Given this list of marker genes DDIT3, HBEGF, EMC10, GRTP1, PPP1R10, HROB, MAFA, DPPA5, FGF1, HSPB8, HADH, UCK1, FBXO15, ACTN4, PAK5, AANAT, VARS1, NHLH2 (nescient helix-loop-helix 2), RARB, ADGRG5, CAPNS1, JUNB, OXNAD1, ZSWIM1, CSF2RA, BHLHE40, CYSTM1, ACP6, FGF4, CFL2, DUSP9, FOXA1, ITPK1, ZEB2, LACTB2, NEK2, MBD3, PDK1, SRC, LSR, RPS8, KCNC1, C22orf15, CIDEA, EVA1B, MSH6, MREG, RIN2, ZIC5 (Zic family member 5), GPC4, EBF4, BARHL1, MYCN, BABAM2, FN1, ADGRE5, FAM120C, TLX2, SET, CCP110, TOP2B, SNTB2, INSYN1, MDK, AMT, SKIL, PIDD1, MEGF11, FXN, REEP3, ECT2, RASAL3, PTCH1, SALL2, MRPL37, ARG1, CFAP20DC, KAT7 (NCBI Gene Id 63437), ERAS, GLRA2, ZRSR2, LIM2, AEBP2 (NCBI Gene Id 121536), WIZ, FARSA, RIF1, PEF1, CST3, RHOF, CRELD1, CRIPTO, PLEKHB1, LRRC61, TSPAN9, GSPT2, GPRC5A, PRMT8, HS3ST3B1, AGTPBP1, RBKS, KRCC1, UBAP1 (NCBI Gene Id 51271), RESF1, G6PC2, KLF2, PYROXD1, ABCB8, AIPL1, SLC28A1, CEBPA, CELSR3, RB1CC1, ZFYVE28, PDGFRB, DYRK3, MYBL2, PPP5C, PRAG1, CPSF4L, FOLR1, OTUD7B, RREB1, RBM41, CFAP161, GSR, SH3BP1, PURB, FRAT1, TMEFF1, SIGIRR, MOK, UTF1, MEIS2, MED21, EVA1A, TCL1A (TCL1 family AKT coactivator A), NACC2, ALKBH7, SRP14, TMEM127, TMEM60, NODAL, RASL10B, ARF4, SPP1, POLR1A, TRH, NUDT4, TMPRSS6, PIMREG, MOBP, ATXN2, ZNF219, BMP4, SPIRE2, CCDC102A, THNSL2, ZC3H3, SPRED1, SLC9A8, ATP11B, ATG14, EIF3L, LGI2, IFITM1, WRAP53, PDLIM1, GRHL3, DCAF4, SDHA, DISC1, LEFTY1, GNL3L, COPS6, ITGA5, TCTN1, DAG1, CSN3, ZNF710, BCKDHA (NCBI Gene Id 593), POU2F3, S1PR2, LIPE, RNF5, ST3GAL3, HNRNPAB, NDUFA4L2, ADGRA2, MDM2, TCF7L2, MYL11, GDE1, CD37, HOXA4, FIGNL1, AMACR, SPRY2, AKAP1, PCGF2 (polycomb group ring finger 2), UBXN2A, COBL, SLAMF8, ZNF76, C9orf152, GLI1 (GLI family zinc finger 1), PLCB3, DLEU7 (NCBI Gene Id 220107), GCA, GPATCH3, ZNF438, CAMK1D, SRSF6, DENND2D, MGAT3, RBP1, DUSP1, PIGL, HOXB4, BRWD1, CFAP91 (cilia and flagella associated protein 91), YWHAG, PTPN6, CNOT9, ANP32A, KIAA1755, UPP1, FAM32A, MUC1 (NCBI Gene Id 4582), INHA, RAB8A, BRSK1, TRIM16, PLA2G10, DUSP4, SPRED2, HSD17B14, CDH1, SLC15A1, GTF2H1, TRIM7, RTBDN, RMND5B, RHBDD2, AS3MT, TM7SF3, SERPINF2 (NCBI Gene Id 5345), DHRS3, SLC25A51, PBX2, INTS3, WNT1, GSE1, RBM14, HMBS (hydroxymethylbilane synthase), TAFA4, HLF, MSLN, ST6GALNAC6, PLXDC1, TYROBP, CRYZL2P, SPATA33, MTSS1, STEAP3, GPA33, FAM91A1, AGPAT3, HOXB13, SBNO2, SPINT4, FEM1B, SULF2, PLK3 (NCBI Gene Id 1263), MME, SMARCD1, ZIC2, MRPL51, ZMIZ1, IER2, UQCRC1, IL3RA, LRRC2, KSR1, SDHD, SLC35D1, B3GNT7, TRIM28, KLHDC7A, ATF3, CYB5RL, GCH1, MBP, RAB10, HOXB1, CIMIP2C, CA4, COG6, DENND10, UBXN8, PPDPF, HOXA5, ENPP4, PPP1R14B, EFNA1, PDCL3, NR6A1, RAI1, HYAL1, MIEF1, KIT, CXCR3, TCP11, MBD6, METTL27, RHOXF2B, TMEM63C, STAT4, FHIP2A, GADD45G, CCN2 (NCBI Gene Id 1490), KDM6B, SMYD1, RNF125, RBPMS, TXLNG, PICK1, WEE1, TEX21P, GDF3, PIK3IP1, H1-2, SLC39A14, STK35, IQGAP3, IFITM2, RHOQ, COL4A1, ENAH, AGPAT1, FAM25A, C1QA, WDR91, ATP5F1E, WFDC2, RITA1, TMEM253 (transmembrane protein 253), AP5S1, G0S2, OTUD5, SPC25 (NCBI Gene Id 57405), NOTCH4, GFOD1, NANOS3, TCF19, VAT1, TRIM17, TLE5, CLN8, ANKRD28, TP53, GTPBP4, PIM3, WSB2 (NCBI Gene Id 55884), PDPN, POU5F1, STK11, PTPRF (NCBI Gene Id 5792), RXRB, PCGF1, PPP1R15B, CALR, FAM171B (NCBI Gene Id 165215), KANK3, SDK1, CLPB, MIS18BP1, SLC12A7 (solute carrier family 12 member 7), ALPL, MCL1, SLC35F2, DEDD, MASP2, PHC1, ZNF770, APOBEC2, GHDC, LEFTY2, SLX1A, TMEM135, UBE2O, GBX2, DACT2, DENND2C, COX17, PORCN, BCAT2, C9orf153, CTSD, SLC7A15P (NCBI Gene Id 100301573), CENPM, RAB20, NR0B1 (nuclear receptor subfamily 0 group B member 1), ING1, GJA1, LRRC75A, SHISA5, DPH3, OAS2, MTHFD1, PTH1R, SMAP2 (small ArfGAP2), GIPC2, ATP2A2, NCOR1, MACO1, MAPK1IP1L, IGFBP2, NFIB, LIN28A, C1orf210, FGF8, NBL1, SOCS3 (suppressor of cytokine signaling 3), AGTRAP, DNAJB6, STRA8, SAMTOR (NCBI Gene Id 154743), IDH3B, ACKR3, ZNF280B, RHD, RPS15A, NTNG2, DNAJC22, MSI2, FUBP3, ITPR1, CCND1, GASK1B, TWF2, SEPSECS, SPEN, VWA8, LDHB, CDX1, C1orf54, CAMK1, TVP23B, SLC4A9, AQP3 (aquaporin 3 (Gill blood group)), PARVB, JAM2, PGPEP1, INPPL1, BCL3, KRT79, ZFP57, STMN2, ZFP64, FOXP4, MTG2, GABBR1, ATG4D, SNAP25, HIVEP3 (HIVEP zinc finger 3), CTSZ, GMNN, here is a description of the gene set: studied in species Mus musculus from publication Delacroix L, Moutier E, Altobelli G, Legras S, Poch O, Choukrallah MA, Bertin I, Jost B, Davidson I (PMID 19884340) All-trans retinoic acid (RA) induces transforming growth factor beta (TGF-beta)-dependent autocrine growth of mouse embryonic fibroblasts (MEFs). We have used chromatin immunoprecipitation to map 354 RA receptor (RAR) binding loci in MEFs, most of which were similarly occupied by the RAR alpha and RAR gamma receptors. Only a subset of the genes associated with these loci are regulated by RA, among which are several critical components of the TGF-beta pathway. We also show RAR binding to a novel series of target genes involved in cell cycle regulation, transformation, and metastasis, suggesting new pathways by which RA may regulate proliferation and cancer. Few of the RAR binding loci contained consensus direct-repeat (DR)-type elements. The majority comprised either degenerate DRs or no identifiable DRs but anomalously spaced half sites. Furthermore, we identify 462 RAR target loci in embryonic stem (ES) cells and show that their occupancy is cell type specific. Our results also show that differences in the chromatin landscape regulate the accessibility of a subset of more than 700 identified loci to RARs, thus modulating the repertoire of target genes that can be regulated and the biological effects of RA. Genes with DNA sequences bound by RARA and RARG in ES cells. Human Gene Set: DELACROIX_RAR_BOUND_ES